The following is a description of a gene set: A protein adaptor that recognizes and binds an RNA molecule modified by C5-methylcytidine. species: Mus musculus Mouse Gene Set: GOMF_C5_METHYLCYTIDINE_CONTAINING_RNA_READER_ACTIVITY, and this is the list of marker genes: Alyreffm4, Ybx1, Alyreffm8, Alyref, Alyreffm5, Alyreffm11, Alyreffm6, Ythdf2, Alyreffm7, Alyref2, Alyreffm9, Alyreffm10, Alyreffm3, Alyreffm1